Given this list of marker genes OSR1, LHX1, WNT11, PKD1, PKD2, PAX2, EPHA4, EFNB2, BMP4, GREB1L, WNT9B, GPC3, EPHA7, GATA3, HNF1B, here is a description of the gene set: species: Homo sapiens The process whose specific outcome is the progression of a nephric duct over time, from its initial formation to a mature structure. A nephric duct is a tube that drains a primitive kidney. Human Gene Set: GOBP_NEPHRIC_DUCT_DEVELOPMENT